The following is a description of a gene set: Short distal phalanx of finger Short distance from the end of the finger to the most distal interphalangeal crease or the distal interphalangeal joint flexion point. That is, hypoplasia of one or more of the distal phalanx of finger. studied in species Homo sapiens Human Gene Set: HP_SHORT_DISTAL_PHALANX_OF_FINGER, and this is the list of marker genes: DVL1, MTOR, WDR35, FIG4, PIGV, IFT122, HOXA13, TWIST1 (twist family bHLH transcription factor 1), EDA (ectodysplasin A), EDA2R (NCBI Gene Id 60401), ROR2, MAPK1, HOXD13, SOX11, PHF6, ABCC9, PRKACA, GLI3, PDGFRB, GGCX, IFT43, CWC27, SMARCA2, EVC2, NOTCH2, NFIX, BRF1, POC1A, PIGW, EOGT, ALG6, ARID1A, WDR19 (WD repeat domain 19), PGAP3, DYNC2LI1, PTHLH, KCNN3, CHST3, GPC3, DLL4, ACTL6B (NCBI Gene Id 51412), CHST11, PIK3CD, SETBP1, CCDC22, ZBTB20, ARID1B, KDM5C, KCNJ8, ERI1 (exoribonuclease 1), COG4, PIGN, LMNA, NOG, PIGL (phosphatidylinositol glycan anchor biosynthesis class L), PRKACB, CRKL, IGF2, PGAP2, MCTP2, JAG1, PIGS, ATP6V1B2, CRIPT, PIGB, IFT52, PIGF, RBPJ, COL10A1, NOTCH1, SMARCE1, SLC25A24, PCNT, ARHGAP31 (NCBI Gene Id 57514), HNRNPR, GJA5, PTCH1, COMP, FLNB, STAMBP, SALL4, FTSJ1, BCR, TBC1D24, RPS6KA3, ZMPSTE24, COL2A1 (NCBI Gene Id 444981), PRMT7, BMPR1B, GPC4, ASCC3, SMARCB1, GNAS, CBFB, GJA8, VPS35L, TBX3, TRPV4, PIGO, TRPS1, FLNA, GNPNAT1, IFT57, EVC, KCNH1, DOCK6, GLI1, CLCN7, FN1, IHH, MGP, ACP5, KNSTRN, POR, NXN, PIGY (NCBI Gene Id 84992), GDF5, ARSL, MAP3K7